The following is a description of a gene set: studied in species Mus musculus Any process that stops, prevents, or reduces the frequency, rate or extent of developmental growth. Mouse Gene Set: GOBP_NEGATIVE_REGULATION_OF_DEVELOPMENTAL_GROWTH, and this is the list of marker genes: Actr3, Sav1, Gdf15, Mir1a-2, Wwc2, D130043K22Rik, Cdkn1b, Ulk1, Ulk2, Fgfr3, Spag9, Ccr5, Nog, Hdac2, Tnr, Adrb2, Gsk3b, Pak1, Rgs4, Rbp4, Sema6d, Slit2, Rtn4, Alms1, Ctdp1, Vgll4, Ostn, Map2, Sema3a, Pi16, Mapk11, Myoz1, Trim46, Cga, Ankrd26, Adrb3, Stk3, Lgmn, Tomm70a, Socs2, Rgma, Atxn2, Stk4, Fgf13, Ptprs, Bbs2, Fstl4 (NCBI Gene Id 320027), Cdk5, Sema6c, Kcnk2, Cfl1, Zfp418, Mecp2 (NCBI Gene Id 338503), Ptch1, Wnt5a, Men1, Wwc1, Ptk2, Cxadr, Dusp10, Mstn, Nrp1, Ntn1, Ppara, Ifrd1, Cdkl3, Cited2, H19, Tbx5, Slc6a4, Jarid2, Gsk3a, Mt3, Wnt3a, G6pd2, Dip2b, Rbm10, Trp73, Hdac6, Dspp, Rtn4r, Mag, Sema4f (sema domain, immunoglobulin domain (Ig), TM domain, and short cytoplasmic domain), Cdh1, Sema3f (NCBI Gene Id 20350), G6pdx, Fxn, Gnas, Tgfbr2, Stc2, Pten, Rgs2, Plxna3, Slit1, Arhgap4, Cdkn1a, Tcf7l2, Sema5a, Ryk, Epha7, Bcl11a, Draxin (dorsal inhibitory axon guidance protein), Atg16l1, Rnf6, Sema3g, Rai1, Plac8, Gja1, Adrb1, Cav3, Spart, Tll2, Wnt3, Yy1, Foxp1, Ttc3 (tetratricopeptide repeat domain 3), Apc